The following is a description of a gene set: studied in species Mus musculus The synthesis or release of products of arachidonic acid metabolism following a stimulus as part of an inflammatory response, resulting in an increase in their intracellular or extracellular levels. Mouse Gene Set: GOBP_ARACHIDONATE_METABOLITE_PRODUCTION_INVOLVED_IN_INFLAMMATORY_RESPONSE, and this is the list of marker genes: Alox5ap, Fads2, Ephx2, Serpine1, Alox5